Given this list of marker genes TAF8, TWIST1, GTF2A2, MED26, MED30, MED12, TAF4, TAF2, GTF2A1, MITF, WNT10B, MED19, MED24, MED18, PAXIP1, MED31, MED6, TAF4B, TAF11, MED1, BCLAF1 (NCBI Gene Id 9774), TAF9, SUB1, MED4, FOSL1, MED8, TAF13, MED16, MED11, SETX, TAF10 (NCBI Gene Id 6881), ERCC6, MYC, NFKBIA, MED17, MED10 (NCBI Gene Id 84246), MED28, MED22, JUN, HNF1B, TAF7, TAF5, MED25, MED15, TAF1, MED21, NKX2-5, ERCC1, MED7 (NCBI Gene Id 9443), CAND1 (cullin associated and neddylation dissociated 1), MED14, PSMC6, MED20, TAF12, MED27, MED23, DHX36, TBP, MED29, TP53, CREB1, SRF, KAT8, HNF1A, CEBPA, XPA, ZNHIT1, TAF6, MED9, TAF3, MED13, NFKB1, here is a description of the gene set: Any process that activates or increases the frequency, rate or extent of DNA-templated transcription initiation. species: Homo sapiens Human Gene Set: GOBP_POSITIVE_REGULATION_OF_DNA_TEMPLATED_TRANSCRIPTION_INITIATION